The following is a description of a gene set: The presence of an abnormal connection between the urethra and another organ or the skin. Human Gene Set: HP_URETHRAL_FISTULA Urethral fistula studied in species Homo sapiens, and this is the list of marker genes: DYNC2H1, MID1, UBR1, WDR35, DYNC2I2, IFT80, DYNC2I1, RNU12